Given this list of marker genes P4HA1, YPEL5, MYCT1, C16orf86, NHEJ1, FBXO32, KIF1B, CDC42EP3, NOL6, SENP6, RAB17 (RAB17, member RAS oncogene family), C1orf21, MARK1, EPB41L1, FARS2, PDLIM2, SLAMF8, NLGN2, HDAC9, PLEKHG3, SPATA25, SOX17, PYCARD, GP1BB, RBMS3, BPNT2, UCN2, TSSK2, COL13A1, PPIB, IL20RA, C2CD4C, TMT1A, MME, ICOS, CKAP2, EMILIN3, TMCC3, CDC25B, NUP50, VNN2, SLC12A7, AK5, DRC1, UCN3, CRIP1, DTX3L, TMEM256, MIA2, FAM181A, SCRN1, RAD54L2, CLDN18, MYO6 (myosin VI), TYW1, EIPR1, CDC42SE1, KCNK7, EIF4E3, KRT222, KCNQ2, EEF2, GABRG2, STMN2, PSPN, DUSP11, MAP4 (microtubule associated protein 4), PTCHD4, GAS2L1, KRT12, MOK, CELSR2, CREBL2, RPTN, NKG7, NEK11, TTYH2, CSRNP1, PHF19, HGD, RESP18, AURKAIP1, PSTPIP2, C19orf25, SLC15A4, ECSCR, CDKN2D, RPL19, CX3CL1, VAMP1, CMTM5, CBL, FJX1, C19orf18, VXN (NCBI Gene Id 254778), PDE7B, C19orf38, NTRK3, SLC26A11, ZNF575, LIPN, ECRG4, CPA6, SLC17A6, FOXO1, PHF20L1, FAU, FGFR3, RPL3L, BEX4, SIRPA, ASPRV1, PTPRN, SNTG2, TMEM65, TRPM1, POC1A, MSRB1, GOLT1A, MIEF2, DUSP22, CSPG4, PILRB, C8orf34, LASP1, TPMT, SHF, NOBOX, PHLDA2, POMGNT2 (NCBI Gene Id 84892), BLNK (B cell linker), E2F2 (NCBI Gene Id 1870), RBBP8, IGFBP2, APH1B, KMT2C, NLRP6, FOXC2, ASXL3, GIMAP1, PEX16, PAK6, SECTM1, PRMT8, RNF125, NXNL2, UAP1L1, LRRC71, ALG14, GLCCI1, SPHK1, SRPK2, LCN8, TP73, RBM15 (NCBI Gene Id 64783), TMEM51, UBE2J2, TAC3, IL18R1, GNAI2, ZDHHC7, DUS2, CLOCK, NEURL1B, YPEL2, CDCA2, LAMP5, GNAT1, OSTF1, THBS1, TREM1, SORCS3, CELF4, NLRC5, CACNG4, GABRR2, GSC2, CLDN3, TAF7, RIPK4, DHX16, RNF130, DOCK6, CLDN16, PCMTD1, SYT17, DTD2, MITF, AMER3, IL17RA (NCBI Gene Id 23765), WSCD1, PLXNC1, CSNK1E (NCBI Gene Id 1454), CALML5, C8G, MZB1, PPM1H, SERTAD2, SCGB3A1, EPDR1, here is a description of the gene set: from publication Hill JA, Hall JA, Sun CM, Cai Q, Ghyselinck N, Chambon P, Belkaid Y, Mathis D, Benoist C (PMID 19006694) CD4(+)Foxp3(+) regulatory T (Treg) cells originate primarily from thymic differentiation, but conversion of mature T lymphocytes to Foxp3 positivity can be elicited by several means, including in vitro activation in the presence of TGF-beta. Retinoic acid (RA) increases TGF-beta-induced expression of Foxp3, through unknown molecular mechanisms. We showed here that, rather than enhancing TGF-beta signaling directly in naive CD4(+) T cells, RA negatively regulated an accompanying population of CD4(+) T cells with a CD44(hi) memory and effector phenotype. These memory cells actively inhibited the TGF-beta-induced conversion of naive CD4(+) T cells through the synthesis of a set of cytokines (IL-4, IL-21, IFN-gamma) whose expression was coordinately curtailed by RA. This indirect effect was evident in vivo and required the expression of the RA receptor alpha. Thus, cytokine-producing CD44(hi) cells actively restrain TGF-beta-mediated Foxp3 expression in naive T cells, and this balance can be shifted or fine-tuned by RA. Human Gene Set: GSE13306_RA_VS_UNTREATED_TREG_DN studied in species Homo sapiens Genes down-regulated in comparison of regulatory T cell (Treg) treated with retinoic acid (tretinoin) versus untreated regulatory T cell (Treg).